Given this list of marker genes STXBP1 (NCBI Gene Id 6812), FGR, DDX21, DNASE1, MAVS, DDX1, ARG1, CCR2, GATA1, UNC13D, CX3CR1, VAMP7, C3, ITGB2, STXBP2, LYN, FCGR2B, POMC, HLA-E, RIGI, F2RL1, DHX36, ITGAM, PLA2G3, ADGRE2, RABGEF1, STX4, VAMP8, SPI1, BCR, IL13, IL13RA2, TYROBP, STAP1, GATA2, PDPK1, FOXF1, BTK, PRAM1, CD177, RAC2, CAMK4, TICAM1, SPHK2 (sphingosine kinase 2), FCER1G, CD84, LGALS9, CXCL6, SNX4, SYK, FES, ADORA2B, GAB2, IL4R, DNASE1L3, FERRY3, FCGR1A, CD300A, here is a description of the gene set: Human Gene Set: GOBP_REGULATION_OF_MYELOID_LEUKOCYTE_MEDIATED_IMMUNITY Any process that modulates the frequency, rate, or extent of myeloid leukocyte mediated immunity. studied in species Homo sapiens